Given this list of marker genes Mink1, Khdrbs2, Gnptg, Zfp945, Ppp1r2 (protein phosphatase 1, regulatory inhibitor subunit 2), Taf5, Fam149a, Bcl11b, Tbca, Fam149b, Htr2a, Wdr37, Clec7a, Clns1a, Slfn4, Mapk8, Sgcb, Ccdc167 (NCBI Gene Id 68597), Kcna4, Skint4, Dlgap1, Map4k5, Serinc1, H2az2, Dhx57, Lypla1, Naaladl2, Nudcd1, Dach1, Abi1, Fus, Patl1, Teddm1b, Tmem47, Mbl2, Enc1, Fndc1, Nr1i2, Grip1, Usp49, Fam178b, Meig1, Dram1, Errfi1, Cct2, Nr1h5, Ank, Dcdc2c, Lilrb4a, Rsbn1l, Fgl2, Clec9a, Cabcoco1, Tmc6, Mnat1, Mthfd2l, B230219D22Rik, here is a description of the gene set: from publication Chen Y, Wang X (PMID 31504780) Genes predicted to be targets of miRBase v22 microRNA mmu_miR_219a_2_3p in miRDB v6.0 with MirTarget v4 prediction scores > 80 (high confidence targets). studied in species Mus musculus Mouse Gene Set: MIR_219A_2_3P